The following is a description of a gene set: Signal transduction through IL1R studied in species Homo sapiens Human Gene Set: WP_SIGNAL_TRANSDUCTION_THROUGH_IL1R, and this is the list of marker genes: TAB1, CHUK, ECSIT, MAP3K1, IL1B, TGFB2, IFNA1, TRAF6, NFKBIA, TNF, MAPK14, IL1RN, NFKB1, MAP3K7, RELA, MAP2K3, IKBKB (inhibitor of nuclear factor kappa B kinase subunit beta), MAP2K6, TGFB1, IL1RAP, IRAK2, IL1A (NCBI Gene Id 3552), TOLLIP, IRAK1, MAP3K14, MAPK8, MYD88, IL1R1, TGFB3, IFNB1, IL6, JUN, IRAK3